Given this list of marker genes ALOX12, here is a description of the gene set: Hepoxilins are biologically relevant signalling molecules produced by certain arachidonate 12-lipoxygenase (ALOX12s). Hepoxilin A3 (HXA3) and B3 (HXB3) have been identified, both of which incorporate an epoxide across the C-11 and C-12 double bond, as well as an additional hydroxyl moiety. HXA3 has a C-8 hydroxyl, whereas the HXB3 hydroxyl occurs at C-10. The epoxy moiety is labile and can be hydrolyzed either by a hepoxilin specific epoxide hydrolase (HXEH) or in acidic aqueous solution to form the corresponding diol metabolites trioxilin A3 (TrXA3) and B3 (TrXB3). Reactome Pathway: Synthesis of Hepoxilins (HX) and Trioxilins (TrX) part of: Arachidonate metabolism studied in species Homo sapiens